Given this list of marker genes Sparcl1, Thbd, Popdc3, Ebf3, Sms (spermine synthase), Ppl, Plpp3, Sfrp2, Ephb6, Six1, Ghitm, Ly6c1, Itih2, Phka2, Capn6, Col6a1, Rab9, Gstt1, Il1r1, Dkk3, Il6st, Fmo1, Gja1, Pax3, Sesn1, Nrp1, Lpar1 (lysophosphatidic acid receptor 1), Col4a2, Col6a3, Nmb, Adam23, B3galnt1, Hlx, Cmbl, Tspan6, Enpp1, Aoc3, Tsc22d1, Ramp2, Art3, Tgfbi, Snai2, Cst3, Gas2, Cdkn2c, Fabp4, Hsbp1 (NCBI Gene Id 68196), Tmem185a, here is a description of the gene set: Genes showing decreasing expression in brown preadipocytes with increasing ability of the cells to differentiate. from publication Tseng YH, Butte AJ, Kokkotou E, Yechoor VK, Taniguchi CM, Kriauciunas KM, Cypess AM, Niinobe M, Yoshikawa K, Patti ME, Kahn CR (PMID 15895078) studied in species Mus musculus The insulin/IGF-1 (insulin-like growth factor 1) signalling pathway promotes adipocyte differentiation via complex signalling networks. Here, using microarray analysis of brown preadipocytes that are derived from wild-type and insulin receptor substrate (Irs) knockout animals that exhibit progressively impaired differentiation, we define genes/expressed-sequence tags whose expression in preadipocytes correlates with the ultimate ability of the cells to differentiate. Many of these genes, including preadipocyte factor-1 (Pref-1) and multiple members of the Wnt signalling pathway, are related to early adipogenic events. Necdin is also markedly increased in Irs knockout cells that cannot differentiate, and knockdown of necdin restores brown adipogenesis with downregulation of Pref-1 and Wnt10a expression. Insulin receptor substrate proteins regulate a necdin-E2F4 interaction that represses peroxisome-proliferator-activated receptor gamma (PPARgamma) transcription via a cyclic AMP response element binding protein (CREB)-dependent pathway. Together these define a key signalling network that is involved in brown preadipocyte determination. Mouse Gene Set: TSENG_ADIPOGENIC_POTENTIAL_DN